Given this list of marker genes COL6A6, INHBA (inhibin subunit beta A), ADAMTS5, ADGRG2, OMD, C1R, IGSF10, DKK2, COL6A1, EMILIN3, LOX, FMOD, PCDH18, THBS1, ALX3, ADAMTS4, LINC02511, MFAP5, COL1A2, CREB3L1, MEDAG, TNFAIP6, ADAM33, NDNF, TWIST2, PODN, MATN4, OLFML1, FNDC1, FN1, MGP, LTBP4, PCOLCE, COL5A1, ADAMTSL4, THBS2, FGF18, TRABD2B, PTHLH, COL3A1, TNFSF9, COL1A1, OGN, ASPN, EMILIN1, CTHRC1, C1QTNF7, EDNRA, EMX2OS, SFRP2, CXCL12, FBN1, EVA1CP4, ISLR, EGFL6, SCARA5, COL14A1, EMX2, IL11RA, PI16, TWIST1 (NCBI Gene Id 7967), RNASE4, SULT1E1, TMEM200B, COL6A2, PDGFRL, IGFBP6, SELENOM, KDELR3, PRRX2, MIR1245A, COL6A3, SOCS1, MXRA5, PENK, MMP19, COL5A2, ITGB3, SPARC, ADAMTS2, ITGBL1, POSTN, VASN, DCN, LMX1B, CHRD, SLC6A2, CA12, DPT, COL12A1, LUM, here is a description of the gene set: Marker genes curated from the annotated cluster as represented in the Descartes Human Gene Expression During Development database. The gene expression program underlying the specification of human cell types is of fundamental interest. The study authors generated human cell atlases of gene expression and chromatin accessibility in fetal tissues. For gene expression, the study authors applied three-level combinatorial indexing to >110 samples representing 15 organs, ultimately profiling ~4 million single cells. The study authors leveraged the literature and other atlases to identify and annotate hundreds of cell types and subtypes, both within and across tissues. Our analyses focused on organ-specific specializations of broadly distributed cell types (such as blood, endothelial, and epithelial), sites of fetal erythropoiesis (which notably included the adrenal gland), and integration with mouse developmental atlases (such as conserved specification of blood cells). These data represent a rich resource for the exploration of in vivo human gene expression in diverse tissues and cell types. Human Gene Set: DESCARTES_FETAL_EYE_STROMAL_CELLS studied in species Homo sapiens from publication Cao J, O'Day DR, Pliner HA, Kingsley PD, Deng M, Daza RM, Zager MA, Aldinger KA, Blecher-Gonen R, Zhang F, Spielmann M, Palis J, Doherty D, Steemers FJ, Glass IA, Trapnell C, Shendure J (PMID 33184181)